The following is a description of a gene set: Any process that modulates the frequency, rate, or extent of toll-like receptor 2 signaling pathway. Mouse Gene Set: GOBP_REGULATION_OF_TOLL_LIKE_RECEPTOR_2_SIGNALING_PATHWAY studied in species Mus musculus, and this is the list of marker genes: Cyba, Tlr1, Tirap, Acod1, Pja2, Trem2 (NCBI Gene Id 83433), Lyn, F2rl1, Nod2, Tlr6, Hmgb1, Mfhas1